Given this list of marker genes MIR20A, PRKN, AMOT, CD47, ARHGEF5, TSC1, S1PR1, MKKS, WASF2, FERMT2, RHOA, MTSS1, LPAR1, RHPN2, NF2, CCN2, SLC9A1, RAPGEF3, CARMIL1, MET, VIL1, ARHGEF10L, ARAP1, SHANK1, SHANK3, GPR65, CLASP2, S100A10, PLEK, ARHGEF15, APOA1 (NCBI Gene Id 335), ALMS1, CDC42, INPP5K, PIK3R1, TTC8, PTGER4, SMAD3, SDC4, MIR21, TGFBR1, MIR149, MTOR, BRAF, BBS4, PHLDB2, PPM1F, PXN, ARHGAP6, RHPN2P1, CFL1, SERPINF2, ABL1, SWAP70, PPM1E, RAC1, TESK1, FRMD7 (FERM domain containing 7), MIR138-1, STMN1, TACSTD2, SYNPO2L, RHOC, SYNPO, TPM1, PAK2, EPHA1, CGNL1, PAK1, ROCK2, PFN1, LIMCH1, ROCK1, TJP1, ARHGEF18, OAZ3, ASAP3, EVL, SYNPO2, TACR1, ARHGEF10, TMEFF2, FLNA, RHPN1, TAC1, PIK3R2, SFRP1, F11R, NRP1, CLASP1, CORO2B, MYOC, RGCC, CCDC88A, PPFIA1, ITGB1BP1, ARHGAP28, DLC1, LIMK1, FHOD1, ACTG1, WNT4, BAG4, CX3CL1, PFN3, WAS, PFN2, RDX, TGFB3, SORBS3, here is a description of the gene set: Human Gene Set: GOBP_REGULATION_OF_ACTIN_FILAMENT_BUNDLE_ASSEMBLY Any process that modulates the frequency, rate or extent of the assembly of actin filament bundles. studied in species Homo sapiens